Given this list of marker genes LTBP1 (latent transforming growth factor beta binding protein 1), IGFBP1, IGFBP3, QSOX1, IGFBP2, HTRA1, CCN1, SHC1, SOCS3, IGFBP6, CCN5, IGFBP7, CCN2, SOCS1, IGFBP5, NEDD9, CCN3, here is a description of the gene set: Human Gene Set: MODULE_474 Genes in the cancer module 474. species: Homo sapiens